The following is a description of a gene set: Genes down-regulated in CD4+ T lymphocytes transduced with FOXP3. studied in species Mus musculus Human Gene Set: ONO_FOXP3_TARGETS_DN from publication Ono M, Yaguchi H, Ohkura N, Kitabayashi I, Nagamura Y, Nomura T, Miyachi Y, Tsukada T, Sakaguchi S (PMID 17377532) Naturally arising CD25+CD4+ regulatory T cells (T(R) cells) are engaged in the maintenance of immunological self-tolerance and immune homeostasis by suppressing aberrant or excessive immune responses, such as autoimmune disease and allergy. T(R) cells specifically express the transcription factor Foxp3, a key regulator of T(R)-cell development and function. Ectopic expression of Foxp3 in conventional T cells is indeed sufficient to confer suppressive activity, repress the production of cytokines such as interleukin-2 (IL-2) and interferon-gamma (IFN-gamma), and upregulate T(R)-cell-associated molecules such as CD25, cytotoxic T-lymphocyte-associated antigen-4, and glucocorticoid-induced TNF-receptor-family-related protein. However, the method by which Foxp3 controls these molecular events has yet to be explained. Here we show that the transcription factor AML1 (acute myeloid leukaemia 1)/Runx1 (Runt-related transcription factor 1), which is crucially required for normal haematopoiesis including thymic T-cell development, activates IL-2 and IFN-gamma gene expression in conventional CD4+ T cells through binding to their respective promoters. In natural T(R) cells, Foxp3 interacts physically with AML1. Several lines of evidence support a model in which the interaction suppresses IL-2 and IFN-gamma production, upregulates T(R)-cell-associated molecules, and exerts suppressive activity. This transcriptional control of T(R)-cell function by an interaction between Foxp3 and AML1 can be exploited to control physiological and pathological T-cell-mediated immune responses., and this is the list of marker genes: CCNA2, CD84, SLAMF6, E2F1, SEMA4A, CCL5, SLFN12, TGFBR3, SELL, IGFBP4, CDK6, CASP1, IL21, P2RY14, IL17RA, TNFRSF25, FOXN3, GZMA, HNRNPA1L2 (heterogeneous nuclear ribonucleoprotein A1 like 2), TNFSF8, CCNF, RUNX2, PARP1, CXCR4, IL4, SGO1, RBL1, FFAR2 (free fatty acid receptor 2), RUNX3, IL4R, GPR171, HAVCR2 (hepatitis A virus cellular receptor 2), IRF4, CASP4, IL17A, CXCR6, BCL2, EOMES, CDKN1A, FASLG, RBL2, TCF3